Given this list of marker genes DNAJC6, ARRB1, ARF1, AP1S3, AP4S1, SH3GL2, BLOC1S1, AP4B1, VAMP7, AP1M1, HSPA8, AP1B1, AP4E1, HGS, VAMP8, AP1S1, AP1M2, CLTA, CLTC, VAMP2, CLTB, CTSZ, AP4M1, DNASE2, AP1G2, CLVS1, M6PR, AP1G1, APP, TXNDC5, GNS, CLVS2, DNM2, AP1S2, CHMP2A, here is a description of the gene set: Lysosome Vesicle Biogenesis Human Gene Set: REACTOME_LYSOSOME_VESICLE_BIOGENESIS species: Homo sapiens